The following is a description of a gene set: Genes having at least one occurrence of the motif TRRCCAATSRN in the regions spanning 4 kb centered on their transcription starting sites. This matches the transcription factor binding site V$NFY_Q6 (v7.4 TRANSFAC). species: Homo sapiens Human Gene Set: NFY_Q6, and this is the list of marker genes: EPM2AIP1, HTR2C, CCDC186, HCP5, PGK2, PITX3, RACGAP1, DLEU2, CIT, HMX1, GNB2, TMEM108, H2AC1, CRABP2, TBX2 (NCBI Gene Id 6909), DLX1, DND1, AMELY, GCA, IMP4, ZNF436, ZNF385A, LRP8, ACR (acrosin), RNF121, SORT1, SESN2, SFRP2, FDPS, MSH2, HIGD1A, HLA-DMA, UGP2, SLC26A9, PRKCB (NCBI Gene Id 5579), CBLB, TNFSF11 (NCBI Gene Id 8600), CDH1, LINS1, ZNF775 (NCBI Gene Id 285971), PRCP, GGNBP2 (gametogenetin binding protein 2), CYP24A1, HLA-DOA (NCBI Gene Id 51034), VCP, NFYC, SKA2, TAF15, CHAC1, SP1, MYO1E, APOLD1, ZFP91, SUV39H1, NUBP2, DCAF11, AGFG2, ARRDC3, KCNJ13, SPRY2, PCDHGA11, BRIP1, AK2, HNRNPR, KLF1, PPM1B, TENM3-AS1, MAEL, EHF (ETS homologous factor), H3C2, SRSF6, ACTL6A, TYSND1, MIR22HG, PI4K2A, THAP9, OARD1, GART, SLC39A4, CTBP2, ASB7, ATOH1, SSBP3, ATP1B4, TTC9C (tetratricopeptide repeat domain 9C), ZBTB5, FGF20, HNRNPUL1, HDAC1, CNTD1, LRATD1, UBXN11 (NCBI Gene Id 91544), CDK1, KANSL2, NKX6-2, COL1A1, PBX1, MSTN, TMCC1, SON, ACYP1, LRRN3, SLC9C2, VSX2, TXNIP (NCBI Gene Id 10628), ZNF436-AS1, IFFO1, GPR50, FDXR, ATF6B, TMEM94, NUMB, BARHL1, SPAG9, ADAMTSL1, CLTA, CDV3, MLH1, OSBPL9, RNF40, COA3, HNRNPC, PTF1A, ZBTB10, IBSP, E2F8, DNAI3, ALB, DLX3, BRWD3, TMEM184C, TAOK3, NAV2, CENPF, HOXB9, HMGA2, ALDH4A1, SEL1L, COX6A2, GRHL3, SFRP1, TAL1, H3-3B, TDO2, SERTAD1, CYLD, OTP, NUP37, KBTBD8, NCEH1, KLHL4, FBXO24, TOP2A, PNOC, MYOCD, DLEU1, HSCB, DSPP, POU3F3, ABCA7, JARID2, ELAVL4, TLE4, MBNL1, SHH, RHOQ, BAHD1 (NCBI Gene Id 22893), H2AC4, CLIC6, RHOA, ARRDC4, MRPS30, ATRX, SEPTIN4 (septin 4), SOBP, ZMAT4, PXMP4, SIX1, PTCH1, NEK2, WASF2, PCNT, SLC4A7, ZDHHC5, HLA-DQB2, SYCP3 (synaptonemal complex protein 3), IER5L, CKS2, PAX6, SPAG7, SIX2, TFCP2, KDM5C, ARX, ZNF711, HMGB2 (NCBI Gene Id 3148), TIAM1, PTMA, NFATC4, MRTFA, PAX1, NEB, WNT8B, FAM76B, SLC25A35, SORBS2, CYP1B1-AS1, STX5, HLA-DRB1, RAB6A, ENTPD7, LDB2, DLG3, ELAC2, ABCF2, OS9, TTN, PIK3IP1, NFYA, TCTA, SIX4, PIK3R3, NOL4, M6PR, PRR11, PLA2G3, MAZ, ALDH6A1 (NCBI Gene Id 4329), CEP57, DDIAS, ARL17A, ENAM, HLA-DRB5, BUB1, ZNF362, DDX4 (NCBI Gene Id 54514), TTK, GGCT, TLL2, FAM110A, GANAB, LHX1, CALM2, SLC12A1, H2BC1, USP21, OSM, C21orf58, OR2L13, GALT, MLEC, STARD7, PARPBP, COPZ1, LRCH4, DCAF7, C12orf57, CCDC115, DGKZ, SMAD2, DDR2, WDR81, RBM4, WNT3